Given this list of marker genes Prkcz, Il4, Tnfsf4, Irf4 (interferon regulatory factor 4), Il17rb, Scgb1a1, Il25, Il18, Arg2, Rara, Gata3, Lef1, Il1rap (interleukin 1 receptor accessory protein), Tnfrsf21 (tumor necrosis factor receptor superfamily, member 21), Il33, Tslp, Sphk2, Lilra5, Il17ra, H2-T23, Tlr4, Nlrp3, here is a description of the gene set: studied in species Mus musculus Mouse Gene Set: GOBP_INTERLEUKIN_13_PRODUCTION The appearance of interleukin-13 due to biosynthesis or secretion following a cellular stimulus, resulting in an increase in its intracellular or extracellular levels.